The following is a description of a gene set: The chemical reactions and pathways involving adenosine, adenine riboside, a ribonucleoside found widely distributed in cells of every type as the free nucleoside and in combination in nucleic acids and various nucleoside coenzymes. Human Gene Set: GOBP_ADENOSINE_METABOLIC_PROCESS species: Homo sapiens, and this is the list of marker genes: NT5C1B, ADA2 (NCBI Gene Id 51816), NT5C1A, ACP3, BLOC1S6, MAPDA, NT5E, ADA, NT5C2, PTGDR, XDH